Given this list of marker genes Hoxc11, Ext1, Hoxa11, Axin1, Slc2a10, Col2a1, Shox2, Osr2, Ihh, Nog, Bmp4 (NCBI Gene Id 12159), Osr1, Bmp7, Hoxd11, Hyal1, Ctnnb1, here is a description of the gene set: Mouse Gene Set: GOBP_EMBRYONIC_SKELETAL_JOINT_DEVELOPMENT The process, occurring during the embryonic phase, whose specific outcome is the progression of the skeletal joints over time, from formation to mature structure. species: Mus musculus